The following is a description of a gene set: Human Gene Set: GOBP_NEGATIVE_REGULATION_OF_CATECHOLAMINE_METABOLIC_PROCESS Any process that stops, prevents, or reduces the frequency, rate or extent of the chemical reactions and pathways involving catecholamine. studied in species Homo sapiens, and this is the list of marker genes: NT5DC2, SNCA, ITGAM, ITGB2, ATP7A